Given this list of marker genes Rpl37rt, Rps5, Rps18, Rps7, Rpl7, Rpl15, Rps24, Rplp2, Rps15, Rpl37a, Rps19, Rps10, Rps2, Rpl36a, Ubb, Rpl24, Rpl36al, Rpl19, Rps9, Rpl29, Rps27l, Rps8, Rps25, Rps26, Rpl23a, Rps4x (NCBI Gene Id 20102), Rpl27, Rpl39, Fau, Rpl3, Rpl18a, Rps28, Rpl9, Rps3a1, Rps11, Rpl39l, Rps20, Rpl4, Rpl11, Rps17, Rpl13, Rpl38, Rpl3l, Rps13, Rpl37, Rps12 (ribosomal protein S12), Rpl14, Rpl6, Rpl26, Rps6, Rps23, Rpl12, Rpl27a, Rpl18, here is a description of the gene set: part of: Ribosome-associated quality control This event has been computationally inferred from an event that has been demonstrated in another species.<p>The inference is based on the homology mapping from PANTHER. Briefly, reactions for which all involved PhysicalEntities (in input, output and catalyst) have a mapped orthologue/paralogue (for complexes at least 75% of components must have a mapping) are inferred to the other species. Reactome Pathway: PELO:HBS1L and ABCE1 dissociate a ribosome on a non-stop mRNA electronically inferred by orthology from the curated human pathway species: Mus musculus